The following is a description of a gene set: from publication Yu M, Li G, Lee WW, Yuan M, Cui D, Weyand CM, Goronzy JJ (PMID 22434910) With increasing age, the ability of the immune system to protect against recurring infections or to control chronic infections erodes. The objective of the current study was to identify gene expression signatures in elderly CD4 T cell responses Human Gene Set: GSE36476_CTRL_VS_TSST_ACT_16H_MEMORY_CD4_TCELL_OLD_DN species: Homo sapiens Genes down-regulated in comparison of untreated CD4 memory T cells from old donors versus those treated with TSST at 16 h., and this is the list of marker genes: WARS1, IL1R1, JPT2, MGLL, GTF2H1, GATB, AGO2, PSAT1, TARS1, PPP2CB, RMI1, SEH1L, GOT2, MRPL20, ALDH2, DNAJB6, KYNU, C1orf216, UTP20, GLB1, HOMER1, LAMP3, PLAAT3, SSRP1, CCL17, PDCD11, PEA15, KDELR2, DPH2, GART, GTDC1, CLCC1, TUBB, TUBA1C, DESI1, PITRM1, RPP40, ERH, NOP56, DAPK1, EIF2B3, CCL22, KIF3B, BTBD3, GNL2, TNFAIP1, CORO1C, LYRM4, PSMB5, EBNA1BP2, TIMM8B, MIPEP, CEP76, NUP62, CTNNA1, NCBP1, CLIC2, GADD45GIP1, IL1R2, DPP3, UBE2A, ATP6V0A2, WDR3, PSMB6, ZNF593, GALR2 (galanin receptor 2), TUBG1, LRRC42, LGMN, STAT1, STT3A, ACOT13, GMPPB, UCK2, IFI30, IL2RA, VDR (NCBI Gene Id 7421), PUS7, GTF2H4, AIMP2, PSMG1, IL15RA, TPI1, C1QBP, G3BP1, BYSL, ZNF189, BATF3 (NCBI Gene Id 55509), PHB1, NME1, TALDO1, NAT10, MYOF, PPP1R10, NUP93, CSTA, TXN (NCBI Gene Id 7295), VDAC3, MRPL12, AK4, CD86, CYC1, RAD51C, SLC43A3, IER3, MCUR1, ATF6 (activating transcription factor 6), MARS1, ETNK1, SLC15A3, BATF, SNX11, IARS1, NDUFAF4, POGLUT2, CSTF2, GORASP2, IRF4, GPR137B, GOT1, TKT, LRRK1, SLC39A14, GARS1, TNFRSF4 (NCBI Gene Id 7293), MRPL17, FUCA1, NUP43, ARHGAP22, SEPTIN10, PSMD13, AARS1, MRPL15, TUBB6, ZNF239, GEMIN4, MRPS12, MLYCD, PSEN2, CTPS1, LY75, TAP1, RBBP8, TRAF1, FH, CCT3, TUBA1B, GLA, TP53BP1, ZBED2, CISH, TUBB2B, EXOSC10, EIF6 (NCBI Gene Id 3692), CEP15, TYMP, STAT5A, NOP16, DNAJA3, CIAO1, VCP, MREG, IL13RA1, SOCS1, ALAS1, TRAP1, MRPL35, CKAP5, TNS3, GINS1, PMM2, CDK2AP1, TBC1D8, POLR3D, KEAP1, SLC3A2, STIP1, CD40, TXNL1, RCN1 (NCBI Gene Id 5954), GNPDA1, PDIA5, FABP5, PAICS, BMS1, PSMB2, PGAM1, CDK4, WDR12, CREG1, ACOX1, SRPK1, SLCO4A1, EIF2B4, PTPRK, PSMD2, CD2BP2, POLR2H, CLTC, PPAN